The following is a description of a gene set: from publication Miyazawa M, Takashima A (PMID 22974541) studied in species Homo sapiens Identification of ROS induced genes on dendritic cells Dendritic cells were incubated for 15 min with or without a ROS inhibitor (DPI), washed extensively and incubated for 30 min with a chemical allergen (DNFB), hydrogen peroxide, and vehicle alone in HBSS containing DPI or vehicle. After washed extensively, the samples were post-incubated for 5.5 h with DNFB, hydrogen peroxide, or vehicle in complete culture medium containing DPI or vehicle. Human Gene Set: GSE20727_CTRL_VS_DNFB_ALLERGEN_TREATED_DC_DN Genes down-regulated in dendritic cells: untreated versus 2,4-dinitrofluorobenzene (DNFB)., and this is the list of marker genes: EXT1 (NCBI Gene Id 3966), EIF3H, THG1L, NOCT, PPP1CB, CRYL1, CIMAP1B, PGM1, ABCB4, SEC63, ID4 (NCBI Gene Id 3400), TMEM108, SDF4, IFT43, KLHL41, PLB1, BTRC, ANKRD26, MANBAL, PRDM10-DT, LIPK, RPS3A, CLEC4M, P4HA2, RPL7A, MIRLET7C, LPAR5, CAPSL, BCR, RPL26, RAB11FIP4, DEXI, RPL12, LINC01551, ALDOC, F9 (coagulation factor IX), GLIPR1L1, SPAM1, OR4A5, SRPRB, ENO3, FHL5, RPS25, SPATA45, TUBB2A, PTP4A2, CYP2B6, LSM14B, ANXA13, OR7E5P, DDX25, OTOGL, EIF2B4, SNORD115-21, ACADVL, SSR4, MXRA5, RPL5, UGGT2, PPTC7, GPX8, RPLP1, CKB, POLK, SAT2, PDIA3, SLC35F5, NSMCE3, SLITRK6, CETN1, CREB3L4, PEX2, UROS, PEX12, EXOSC7, GTF2H1, DYNC2LI1, L3MBTL4, RBM4, TPTE2P6, SLC30A1, DHRS3, CLPB, DNPEP, PUM3, ASAH1, ANK1, SYTL3, VPS18, ANKRD62, RPL22, TMEM216, NEXMIF, OXSM, HSPB1, RNF122, FBXL19-AS1, TBL1X, PIGM (phosphatidylinositol glycan anchor biosynthesis class M), LINC00910, RPL15, SEPHS2, ACAA1 (NCBI Gene Id 30), MLYCD, KDELR3, GRSF1, FGL1, CATSPER2P1, ZNF627, EYS, REP15, UBXN10 (UBX domain protein 10), SNORD116-25, RPL11, GDAP2, SQSTM1, PAQR7, EPS8L2, PNLDC1, RPL17, ZNF223, SIL1, RNF7, HSD17B4, INTS13, PDK4, MTR, RPL9, SLC36A2, PERP, TENT5D, BMS1, RPS7, ATP6AP1L, SLC16A13, TRIM27, TMEM241, CLNK, PABPC1P2, HNF4G, OR6C76, NOL4L, SRSF11, CHCHD3, PKIB, CCDC158, ABCG1, TMEM232, RSPH3, NPM1, SNX15, USP4, VAT1, VGLL4, IRAK3, TKFC, SERTAD3, IGBP1, NF1, ANKRD50, AGGF1, SUPT3H, CALHM6, CENPBD1P, PGBD2, STAP1, EIF2A, CRKL, TMPRSS15, SNORD1B, SLX9, GGACT, RIOK3, VEGFA, TARS2, TGFBR2, PRDX5, SNORD1A, RPL27, ISLR, GRK5, TSPAN4, HEMGN, SURF6, RILPL1, UQCR11, RPS20, PDZRN4, RPSAP52, MOB1A, AKAP3, RPL24, LYZL1, FKBP14